Given this list of marker genes DLG4 (NCBI Gene Id 1742), PENK, SLC4A10, APOE (apolipoprotein E), TUBA1A, MYG1, GAD1, ATP1A2, DPP4, LRRK2, CRBN, CRH, NLGN2, PRKCE, GRN, TNR, here is a description of the gene set: species: Homo sapiens The specific movement from place to place of an organism in response to a novel environment. Human Gene Set: GOBP_LOCOMOTORY_EXPLORATION_BEHAVIOR